The following is a description of a gene set: studied in species Homo sapiens Human Gene Set: HP_DERMOID_CYST Dermoid cyst A congenital subcutaneous cyst that arises from entrapment of skin along the lines of embryonic fusion. In contrast to epidermal cysts, dermoid cysts tend to contain various adnexal structures such as hair, sebaceous, eccrine or apocrine glands. Dermoid cysts are present at birth, and are indolent, firm, deep, subcutaneous nodules. They are often located on the head and neck, and rarely in the anogenital area. Dermoid cysts are slowly progressive and can grow to a size of 1 to 4 cm., and this is the list of marker genes: TFAP2A, MNX1, SYT1, ZSWIM6, MSX2, VANGL1, ALX3